Given this list of marker genes NSD1, NEK8, BBS12, NF2, ZIC2, IRAK1, TWNK, PNP, MT-TE, STAG1, LYST, PXK, ABCA4, POLR2A, MED12L, MYT1L, VPS13B, SPATA7, PGK1, ATXN8OS, CPLX1, CAPRIN1, CSF1R (NCBI Gene Id 8156), GNAQ, PTCH1, EZH2, ERCC2, ELN, H4C5, SGCE, PANK2, GABRA2, SNORD116-1, GATA4, GPC4, BBS5, THOC2, SLC7A14, CHI3L1, BRCA2, TCF12, VPS13C, CTNNB1, PIGA, ESPN, GLRA2, DCDC2, GDF6, TTLL5, UBE3A, POMC, TAOK1, RREB1, GALT, YY1, LHX1, DEAF1, PITPNM3, CASP2, HCRT, UBAP2L, MT-TS2, BBS7, IDH3A, LMAN2L, NDP, SPAST, HEPACAM, FOXC2, AIRE, CFI, GNB5, SEMA3E, CNNM4, PIGL, PEX14, SLITRK2, HLA-A, SLC1A3, GLS, AFG2A (AFG2 AAA ATPase homolog A), ACAT1, PIGQ, SIGMAR1, SOX11, UNC80, SCN1A, CASZ1, IGF1, AHSG, HUWE1, ERCC3, JAK2, OPHN1, CDKN1A (cyclin dependent kinase inhibitor 1A), SOX6, CDK13, ACTL6B, MSL3, EIF5A, TRAPPC6B, FGFR1, ATXN3, REEP6, ENTPD1, MPLKIP, TDO2, VPS13D, CDC73, GRIN2A, WLS, PEX13, MAPK10, MYOC (myocilin), MAPT, AGO2, NFASC, SREBF1, SNORD118, SLC5A2, STX1A, GJA8, SNAP25, IDS, ADH5, CHD3, ACOX1, ZNF699, DICER1, RELN, DAOA (NCBI Gene Id 267012), USP7, EML1, DISP1, CDH11, EYS, HDC, GNE, CDC42, SLC6A17, SPR, ASH1L, DMPK, EDNRA, FIG4, EIF2S3, NFS1, SNCA, MED12, CHRNA7, NOTCH2NLC, TKT, NPC2, AP3B2, CTBP1, HIRA, VSX1, ZMIZ1, USP48, COMT, TNIP1, DLG3, SPG11, SMARCA4, WASF1, KCNJ11, STAR, PRKD1, SMC3 (NCBI Gene Id 9126), DPYS, DPH2, ZSWIM6, PGAP1, SLC25A13, NABP1, UBA2, CC2D2A, GRIA1, NEUROD2, MUTYH, RORA, DZIP1L, TOE1, HTRA2, RBP3, ST14, SLC25A1, MEIS2, HARS1, SLC25A22, EIF4G1, GUCA1B, IMPG1, NSUN6, PPP2R1A, CHD1 (NCBI Gene Id 1105), PRODH, CHCHD10, PPM1D, BSCL2, CACNA1H, ITGB6, ZNF711, PRPF3, IMPA1, LETM1, ATP2B1, HMGA2, TBC1D23, VCP, UBE4B, BCORL1, PEX5, RSPRY1, USH1C, AGRN, GLYCTK, TMTC3, SMAD4, MPV17, ALG13 (ALG13 UDP-N-acetylglucosaminyltransferase subunit), SRRM2, NDST1 (N-deacetylase and N-sulfotransferase 1), BLTP1, HLCS, XK, CBS, PRDM8, HCN1, PEX10, DPYD, NCAPD2, KANSL1, RORB, IKZF1, MATR3, TULP1, SARDH, PODXL, AIPL1, POMT1, POLD1 (DNA polymerase delta 1, catalytic subunit), AHI1, COL8A2, KNL1, ARID1B, TREM2, DPYSL5, MSH2, CEP78, ARMC5, PRKAR1B, EIF4A2, PPP2R5D, NRL, PCNT, GNS, CHRNA4, EEF1A2, DCHS1, HAL, BICRA, AFF2, GTF2I, KRT3, WARS1, WARS2, DMXL2, RPE65, DNAJC19, HIVEP2, BCL11B, FCGR2B, TBCD, PTPA, TIA1, PMS2, TBX4, PRPH, LIMK1, SLC18A2, PON3, AP2M1, DLG4, FRRS1L, ATP6V1B2, KAT6A, BBS2, WHRN, GUCA1A, TET3, SNORD115-1, CTLA4, ATXN2, AP4M1, NPRL3, ERAP1, TASP1, SEC24C, TSC1, PFN1, IFT172, POMGNT1, NBEA, TRAPPC14, GLI2 (GLI family zinc finger 2), CRX, KLRC4, AUH, AP1G1, L2HGDH, PRKN, HNRNPR, EIF2AK1, TGIF1, UCP2, FGD1, PSMC3, SHQ1, KRT81, LSS, WDR62, METTL27, PAH, ARSG (NCBI Gene Id 22901), SPTBN1, TLR3 (toll like receptor 3), C4B, ATF6, ZNF292, XPA, CD3D, ASXL1, TARDBP, COL1A1, PPP2CA (protein phosphatase 2 catalytic subunit alpha), OPTN, LRAT, MAPK8IP3, SDHC, APOL2, DCN, FANCL, GNAS, SORL1, PDSS1, MANBA, KLHL7, C12orf57, ATXN7, CHD5, NECAP1, TRAF7, TGFB1, TRAK1, UBA5, PRPF6, HEXB, LARP7, CHAT, CDKN1C, WDPCP, PEX1, SCN4A, KIF15, CDKL5, CUL4B, TRIM32, UQCC2, TP53, GDAP2, CAMK2B, PCDH19, KCNC2, SETD2, QRICH1, DYM, GABRA5, SPG21, KMT2D, ALAD, RPL10, DLL4, SUCLA2, ZNF462, ADAT3, SUGCT, ESR1, PCNA, HNRNPK, NAA10, CHRNA2, GATM, PSMD12, EPM2A, PPP2R2B, GNAT2, RABL3 (NCBI Gene Id 285282), NLGN4X, KIZ, RSRC1, ZMYND11, MEFV, PARK7, CYFIP2, TIMM50, HDAC4, KRT5, SIX3, TMEM147, SIK1, EPCAM, PDZD8, WAC, SATB1, DNAJC13, NOVA2, NECTIN1, RBM12, USH1G, KLLN, PDE6B, DHX38, ARL6, PEX19, ADAM9, ACY1, PREPL, CC2D1A (coiled-coil and C2 domain containing 1A), TMEM240, IGHG1, MKKS, SLC52A2, KCNK9, RUSC2, DRD2, MT-TQ, LINS1, ERCC5, CRBN, CHEK2, CACNA2D1, RTL1, SON, FAR1, DPAGT1, AKT1, ATP7A, LZTFL1, SUCLG1, IL6 (interleukin 6), PRPF8, NTRK1, MLX, SYN1, SLF2, NAGLU, SCN8A, GABBR1, PDPN (NCBI Gene Id 29912), FOXG1, DNAJC6, SLC38A3, UNC13A, IGF2, FLCN, CALR, ZNF408, CACNA2D4, AIP, ASXL3, UBE4A, OPN1LW, SLC9A6, LEMD3, RAF1, UFD1, VPS13A, TUBB3, IQSEC1, ODC1, MC2R, OCA2 (NCBI Gene Id 4948), NEXMIF, GTF2H5, KCNA1, CORO1A, SLC6A1, EBP, SLC45A1, CCND1, KDM1A, CDH2, ALDH3A2, TMLHE, TUBB2B, COQ5, CLCC1, TSHB, RLBP1, TBP, RP9, PRKAR1A, NEK2, PDE6G, MTHFR, CRLS1, KIAA0319L, IFT140, BBS9, SOD1, NPHP1, HEPHL1, TACO1, VPS35, GBE1, TGFBI, YWHAG, JAM2, NRAS, LUZP1, SETBP1 (NCBI Gene Id 284262), VPS37D, DHCR7, NIPA2 (NIPA magnesium transporter 2), SOX5, PDCD1, PHF21A, FTCD, SUPT16H, RGS9BP, LGI3 (NCBI Gene Id 203190), JRK, C1QTNF5, RTN4IP1, ABCC8, CLN8, EPB41L1, MT-ND4, SARS1, TLK2, LRIG2, NF1, NALCN, KDM5A, TAF15, RGS9, ERI1, ABCA7, MAK, PPP3CA, PAK3, ANXA11 (NCBI Gene Id 311), SPRED1, HNRNPC, RNF113A (NCBI Gene Id 7737), RDH5, SMARCD1, ELOVL4, ATP6V1A, PSAT1, KRT86, TNFAIP3, TTC19, PMS1, OTUD5, PIGS, KPTN, PRPH2, SPTAN1, PUM1 (NCBI Gene Id 9698), SRY, NOD2, FLG, TRANK1, SPOP, C4A, CHAMP1, BUD23 (BUD23 rRNA methyltransferase and ribosome maturation factor), CLTCL1, CEP290, ERCC8, PLXNA1, ATP6V0A1, CDK8, APP, UCHL1, IFNG, DPH1, RP2, MSH6, FGFR3, PDE2A, IL12A, FGF13, IVD, WNT10A, FGF8 (fibroblast growth factor 8), PDE6H, DNM1, GLT8D1, ADGRV1, MMUT, PAX4, P2RY11, NPRL2 (NPR2 like, GATOR1 complex subunit), SMARCA2, ADH1C, NLRP1, KIAA1549, CTNNA2, NNT, SPEN, RGR, PIGG, JPH3, DALRD3, DEPDC5, DGCR2, ADA2, EBF3, CHST6, RBL2, NHS, RIMS1, TXNRD2, UBE2L3, NPHP3 (NCBI Gene Id 27031), VANGL1, POLE, SLC5A7, DHX30, ASPM, SLC19A3, LEPR, PDGFB, LHCGR, SLC7A7, SLC32A1, LAS1L, DYNC1I2, NEFH (NCBI Gene Id 4744), SKI, FZR1, STT3A, RPS20, TUBB4B, NMNAT1, AP4B1, STAT5B, OCRL, TOR1A (NCBI Gene Id 1861), FOSL2, TEK, SLC2A3, TRIM44, SIN3B, DLK1 (NCBI Gene Id 8788), NSD2, RAD21, RPS23, FTL, GABRB2, ZNF513, MICU1, LMX1B, PLAG1, ITPR3, AVPR2, PSMB1, HNRNPA2B1, ITGAM, SMPD1, SLC9A7, MYO7A, SLC1A4, ACSF3, CCNK, SOX2, CILK1, CTCF, PUS7, IFT88, WFS1, GJA5, MAOA, SLC6A4, COL4A1, CACNA1C, FLII, CDHR1, LMNB1, TMEM106B (NCBI Gene Id 54664), PGAP3, SPG7, TTI2, RFC2, CISD2, C19orf12, REV3L, TRAPPC10, MID1, ITPR1, NAA15, BLK, HSPG2, SYNGAP1, CRYGC, NUMA1, ZFPM2, MT-ND1, NTRK2, NBN, RARA, TUB, CCBE1, CARS1, GNB1, TMEM138, MTSS2, RNF135, SEMA4A, GAN, ZEB1, BRF1, ZEB2, GRN, SRPK3, SLITRK1, UBE2A, KRT12, IDH3B (NCBI Gene Id 3420), GRIN1, SLC4A1, PWRN1, BCR, CACNA1G, IFT74, AHCY, RLIM (NCBI Gene Id 51132), PDE6C, CELF2, HECW2, MC4R, CLCN2, DNASE1, CEP250, SDHB, SYT2, KCTD17, POLG2, CA4, KAT8, DHPS, GNB3, PTPN22, USH2A, MT-CO1, SNRPN, CLTC, TICAM1, LEP, ZBTB7A (NCBI Gene Id 56976), TTC8, ASCC3, IMPDH1, MPL, WWOX, DDX3X, MCOLN1, KMT2C, SDHD, PRNP, PTEN, NDN, CLCN4, NKAP, PEX12, DAO, BMS1, DSG4, ABCA12, PDE4D, KDM4B, ZDHHC9, GRHL2, TAT, LIG4, PUS3, DHDDS, CD247, CRKL, SHOC2, ATG7, TAF4, RDH12, KDM3B, FCGR3B, IRF5, DCT, CASR, ATP1A1, KCNN2, IL12B, BAZ1B (bromodomain adjacent to zinc finger domain 1B), DDB2, RAC1, GRIK2, LRMDA, UPF3B, MTPAP, ARPC4, ITM2B, SRPX2, NEK1, PIGP, CD3E, RNF216, TMEM237, TTC5, FERRY3, RAP1GDS1, PLCH1, CRH, PRKACA, PYCR2, GFM2, RNU7-1, SLC6A19, PARS2, SMO, TELO2, HECTD4, MBOAT7, RAB11B, APTX, DGCR8, NKX2-1, NIPA1, GNA11, CCNF, SIN3A, TNPO2, SVBP, ARSA, SUFU, BBS10, TERT, FAT4, SPTLC1, CDH23, MED25, NSUN2, PEX2, CTSH, STEEP1, KCNAB2 (potassium voltage-gated channel subfamily A regulatory beta subunit 2), NEUROG1 (neurogenin 1), CEP152, IMPG2, GRIN2D, ZNF423, INPP5E, IRF4, POGZ, CLDN10, CLCNKB, VARS1, CAMTA1, CYP11B1, HNF1A, GABRD, AQP2, KAT5, PIGY, KRAS, LRRK2, KCNJ1, SNX14, BRD4, KMT2B, IARS1, NLRP3, TLCD3B, ASAH1, RHO, TBC1D2B, MCAT, KYNU, GJA1, PNKP, ADCY3, ALKBH8, TMEM270, UROC1, FANCD2, HSD11B2, GRIA2, H3-3A, EFEMP1, MED13, MEF2C, GALNT2, TACSTD2, IQCB1, PIGH, TAF6, MMP23B, PCARE, GTF2E2, SLC45A2, ZBTB16, CFH, GAS1, SOX4, DCX, IMPDH2, PPP1R12A, CABP4, BANK1, RP1, AMACR, IKBKG, GRIN2B, ATP1A2, MT-TL1, JARID2, GJC2, GRM7, TMEM231, ANKRD11, PLCB4, CNGB1, KDM5B, EFL1, IRF2BP2, CDKN2C, SCARB2, AP1B1, DRD4, RALA, MT-TW, INSR, PON1, ELP2, FTSJ1, PACS1, KDM5C, ADNP, PUF60, USP45, HPSE2 (heparanase 2 (inactive)), RIC1, NSDHL, KRT14, PEX26, ATP5F1B, KDM6A, RIMS2, CSGALNACT1, ANTXR1, ATM, CHKA (choline kinase alpha), TNF, SLC12A2, PEX3, ALDH4A1, SNRNP200, AP3D1, CYLD (NCBI Gene Id 8010), VPS16, SLC12A3, AGPAT2, CTNS, APOL4, CLDN16, MAB21L1, SLC1A2, CTSF, TCEAL1 (NCBI Gene Id 96422), CHRNB2 (cholinergic receptor nicotinic beta 2 subunit), TSC2, SLC39A4, SHMT2, IRF6, AGA, CHD7, RAB28, AVP, SLC18A3, BSND, EXT2, PALB2, ALG11, KMT2E, FGFRL1, ATP1A3, CR2, USP27X, TNFSF4, PROM1, SCN9A, CYP1B1, EXTL3, SMARCB1, FOXH1, ERCC4, ECM1, RERE, CYP11B2, ADH1B, TNIK, DPF2, DIP2B, TUBA1A, PALLD, ACSL4, PPP1R21 (protein phosphatase 1 regulatory subunit 21), NAA60 (NCBI Gene Id 79903), MT-TF (mitochondrially encoded tRNA-Phe (UUU/C)), SLC24A5, PIGW, TANC2, ESS2, DLL1, PWAR1, RP1L1 (RP1 like 1), VAMP1, SYK, PCGF2, EHMT1 (euchromatic histone lysine methyltransferase 1), PRORP, NPTX1, ATP13A2, NDE1, SACS, ARID2, PRKCG, KMT5B, MFRP, TRIP12, ARNT2, GBA1, HNRNPH2, KCNH5, BCKDK, RRM2B, HGSNAT (heparan-alpha-glucosaminide N-acetyltransferase), COL17A1, DRAM2, THRB, PIEZO2, SCN3A, KARS1, PNPLA6, MT-ND6, TOMM40, GLA, PIGV, SAG, HNRNPA1, NOTCH3, ANAPC1, CACNB4, POLA1, RNF125, UNC119, HPS6, CRELD1, UBQLN2, CLCNKA, MBD5, NR2F1, KLF13 (NCBI Gene Id 51621), SATB2, MAX, NUS1, FUZ, LNPK, TBX1, GLDC, ALG9, FZD5, PDE6A, OTC, CIT, SLC3A1, ACADS, KIF14, ARG1, ARL2BP, AASS, CLCN3, NPHP4, EFHC1, P4HA2, FAS, NOP56, ZIC1, ARVCF, NFIA (NCBI Gene Id 4774), FBLN5, MFF, PKHD1, SLC35C1, ZFYVE26, POLH, FBXW11, PEX11B (NCBI Gene Id 8799), INTS1, EIF2B1, GALC, ELOVL5, ARCN1, TLR7, RNU4-2, FSCN2, SZT2, SGSH, HLA-DQB1, LTBP2, SCAF4, MYD88 (NCBI Gene Id 4615), CACNA1F, SETD5, SLC7A6OS, SEC23B, ANK3, DLAT, IFNGR1, MSTO1, BBIP1, TMCO1, CCR1, KCNQ3, TM4SF20 (transmembrane 4 L six family member 20), HESX1, MAN1B1, GRB10, PIK3CA, MOG, CACNA1A, CDK10, BRCA1, NLGN1, CDON, BCL11A, FRMPD4, NCF1, SLC35A3, HADHA, MC1R, TREX1, COL13A1 (collagen type XIII alpha 1 chain), STAG2, STS, PERCC1, LGI1, TBL1X, AMPD2, PCYT1A, DYRK1A, BPTF, ARHGEF18, NR3C1, PRKCZ, NPAP1, PML, GABBR2, CREBBP, ADSL, PIGO, TSHR, TFE3, RFX7, ATR, EMC10, NACC1, USP9X, KIF5C, GJB6, CACNA1B, PROKR2, ANKRD17, NAGS, SLC13A5, VAPB, RHOBTB2, TBL1XR1, SRP54, SCLT1, HPS1, SDCCAG8, CSNK2A1, GCH1, TARS1, GNAI1, WDR4, AP4E1, SLC19A2, SMC5, SLC46A1, KDM6B, FKBP6, SLC6A8, DENND5A, STX1B, TRIO, WBP4, MAGEL2, RPS6KA3, KY, DOLK (NCBI Gene Id 22845), RPGRIP1, ERBB4, SLC25A4, RBBP8, MLXIPL, DOCK7, TRAF3, POU3F3, RPGR, DRD3, MEG3, PLXND1, JAZF1, TMEM222, COASY, SCAPER, SYNJ1, GTF2IRD1, FMR1, GATAD2B, ZNF365, MAN2B1, MAPK1, NIPBL, VAMP2, IQSEC2, PSAP, TIAM1, CNGA3, SMARCE1, EP300, NAA20, MSX1, CPT1A, FRA10AC1, HOXA2, TRIM8, SETD1A, SNCAIP, OPN1SW, PTCHD1, GABRB3, PDE11A (phosphodiesterase 11A), PHGDH, MIR17HG, TGFBR2, JMJD1C, TNFRSF1A, ELOVL1, HLA-DRB1, PPARGC1A, JAG2, ETS1, STAT3, B4GALNT1, CEP85L, DNM1L, CERKL, NAPB, USF3, ERLIN2, ZNF526, GABRA1, UNC93B1, GAMT, AHR, MTOR, PTPN3, COG5, BBS1, FLI1, TYROBP, SYN2, NFIX (NCBI Gene Id 4784), FBXL3, PDZD7, ATRX, TPR, PACS2, HK1, AP4S1, MMACHC, AFF3, PHIP, DLD, IL10, GUCY2D, CEP19, GJB2, SQSTM1, FLT4, RNF168, UBAC2, HSD17B10 (NCBI Gene Id 50828), TBCK, PPIL1, ATXN10, AFG3L2, KCNJ13, COG6, MT-TT, MLH1, AGBL5, PON2, ATP9A, GUSB (glucuronidase beta), DDX6, ZBTB18, WDR26, TOPORS, CDH15, ATP7B, ALS2, FBXO28, CHMP2B, DNAJC12, KCNA4, PAK2, SLC41A1, PGM2L1, GCSH, DGCR6, NLGN3 (neuroligin 3), ZBTB20, MRAP, CUX2, ANG, CFAP410, GPR101, PHACTR1, NAA80, OTX2, ZFX, APOE, ZMYM3, PCDH15, CERT1, DRD5, BCAP31, SHH, PITRM1, SMG8, RD3, BEST1, DCTN1 (NCBI Gene Id 82109), EIF4H, POU4F1, ANGPT2, TMEM67, PPOX, AGO1, COG3, ASL, BCOR, HERC2, ABCA2, USP8, AHDC1 (NCBI Gene Id 27245), PRRT2, H4C11, ADCY5, NR4A2, ABCB7, LCA5, POC1B, TMEM216, GTF2IRD2, PRPF31 (pre-mRNA processing factor 31), PINK1, MACF1, KCNV2 (potassium voltage-gated channel modifier subfamily V member 2, NCBI Gene Id 169522), SRSF2, WBP11, DDX59, CLRN1, BMPR1A, NARS1, SH3KBP1, DDC, TBK1, PLA2G6, METTL5, NRCAM, CEP104, AARS1, TCF20, PRR12, WDR45, LRP1, MT-CO3, AP3B1, PSEN1, PDCD6IP, FUS, OVOL2, ARID1A, NODAL, ELP1, DHTKD1, MYO9A, MGAT2, TBX2, SBDS, GLI3, CNOT3, PRPF4, MEN1, KMT2A, CUL3, DKK1, IFT27, OTUD6B, CLIP2, CNGA1, YME1L1, BCS1L, DNMT3A, KIF11, CLTRN, FA2H, TLR4, MT-CO2, ITGB4, SIM1, CASK, NAXD, ROS1, ACBD6 (NCBI Gene Id 84320), ZMYM2, SCN1B, STIL, ROM1, CYP27A1, KRT83, TPM2, PLEC, FMO3, SH2B1, MRPL39, BAP1, TOGARAM1, FBXO11, AP1S2, MBTPS2, CAT (catalase), CHD8, SYT1, HMGCL, FOXC1, ALPL, POLG, CHMP1A, KCNT1, FOXP1, STAT4, NONO, CHD2, HLA-B (major histocompatibility complex, class I, B), PCSK1, MECP2, U2AF2, KCNJ10, RUNX1, GLE1, TRPM3, SASS6, ZNFX1, NAGA, TRAPPC9, RAX2, CDC42BPB, NPM1, RAB39B, PTRHD1, GNAO1, OFD1, CNKSR2, WASHC4, PIDD1, SCN2A, SMARCC2, FOXP2, DNMT1, MKS1, MAN2C1, KCNJ5, CNGB3, RTN4R, PEX6, CDKN1B, AUTS2, DNAJC21, PEX16, PRCD, CDKN2A, CAMK2G, NAT8L, AQP4, TP63, CRIPTO, FOCAD, FAM161A, CDKN2B, PIEZO1, CIB2, CFAP418, TET2, GPR143, SPP1, BBS4, GNB2, XPC, PIKFYVE, MTRR, APC2, SETD1B, SRCAP, ALMS1, CNTNAP2, IL12A-AS1, MFSD2A, IL23R (interleukin 23 receptor), TTI1, SHANK3, ATP10A, HERC1, MED13L, MT-TH, CIC, CDC40, HTRA1, ALK, PGAP2, RAI1, KCNB1, UBTF, FIP1L1, BLOC1S5, ARL3, NFIB, GABRG2, TYR, SPECC1L, MADD, NHLRC1, PAX6, GLUD1, BRAF, MID2, TPH2, LINGO1, RPGRIP1L, CDK19, CACNA1D, SBF2, KPNA3, PDGFRB (platelet derived growth factor receptor beta), TAS2R16, ARX, HPRT1, RTTN, PSEN2, ERCC6, OPN1MW, MERTK, PRDM16, HDAC8, CARS2, DPP9, TCF4, ADGRL1, STXBP1, MMADHC (NCBI Gene Id 27249), SOX3, NTNG1 (netrin G1), PLCD1, TBL2, CAPN15, DDB1, ABCD1 (ATP binding cassette subfamily D member 1), GM2A, MT-ND5, TUBG1, CST6, HTR2A, HNF1B (HNF1 homeobox B), CBL, KL, SLC4A10 (NCBI Gene Id 57282), TAF1, ERCC1, TIMM8A, TBR1, NTNG2, HTT, ALDH5A1, GRIA3, ALDH18A1, MAP1B, IL1RAPL1, FGF12, NR2E3 (NCBI Gene Id 51736), MN1, TRRAP, ATP2A2, CRB1, ALG14, SPART, FGF14, DPP6, MKRN3, SMC1A, UBE3C, SLC2A1, MCTP2, DNAJC30, GP1BB, SHROOM4, TBC1D24, KCNA2, SLC25A36, PIGF, TNRC6B, GIGYF2, here is a description of the gene set: Atypical behavior Atypical behavior is an abnormality in a person's actions that can be controlled or modulated by the will of the individual. While abnormal behaviors can be difficult to control, they are distinct from other abnormal actions that cannot be affected by the individual's will. Human Gene Set: HP_ATYPICAL_BEHAVIOR studied in species Homo sapiens